The following is a description of a gene set: studied in species Mus musculus Genes predicted to be targets of miRBase v22 microRNA mmu_miR_669h_5p in miRDB v6.0 with MirTarget v4 prediction scores > 80 (high confidence targets). Mouse Gene Set: MIR_669H_5P from publication Chen Y, Wang X (PMID 31504780), and this is the list of marker genes: Syn3, Tlcd4, Hycc2, Usp49, Zfp953, Cdca7l, Tomm70a, Prkca, Zfp438, Zmym2, Ywhaq, Kcnj3, Ino80d, Lgals8, Zfp811, Atl1, Ssbp3, Echdc1, Ccr3, Ghsr, Camta1, Simc1, Ctnna2, Ints6l, Jam2 (junction adhesion molecule 2), Ywhah, Zfp24, Anks1b, Neu4, Ptprz1 (NCBI Gene Id 433999), Slc9a1, Rgr, Stag1, Anxa11, Abcg4, Ephx3, Efr3a, Zfp719, Anxa7, Amigo2, P2rx7, Epha4, Slitrk4, Hoxc10, Ep300, B3galt2, Utp23, Map1b, Vegfd, Gbp9